Given this list of marker genes Slc30a1, Slc38a2, Nlgn1, Stxbp5, Slc22a2, Lin7b, Cacna1d, Prkca, Asic1, Rab5a, Cacna1e, Ddc, Slc32a1, Prkn, Gpr158, Mctp2, Syt11, Snca, Osbpl2, Slc6a7, Syt9, Cplx2, Th, Stxbp3 (syntaxin binding protein 3), Htr1d (5-hydroxytryptamine (serotonin) receptor 1D), Rph3al, Wnt7a, Slc22a3, Nf1, Efr3a (NCBI Gene Id 97947), Synj1, Rab3a, Snapin, Septin5, Syn2, Slc17a8, Slc18a2, Lrrk2, P2rx7, Slc28a2b, Slc1a7, Snap91, Snap25, Stx19, Ica1, Nat8l, Ppp1r9a, Cplx1, Vamp2, Xbp1, Fbxl20 (NCBI Gene Id 97750), Htr6, Psen1, Lin7a, Camk2a, Sv2a, Sptbn2, Itgb1, Cln8, Stxbp1, Stx4a, Fev, Adora2a, Slc17a6, Syt4, Rap1b, Unc13b, Stx3, Prepl, Slc17a5, Itgb3, Stx2, Slc6a8, Lin7c, Rims2, Git1, Pnkd, Tprg1l, Hcrt, Slc6a6, Sncg, Flot1, Cacna1b, Slc6a11, Otof, Ncs1, Edn3, Pdzd11, Cask, Cacnb4, Kcnh1, Prkcg, Slc28a2, Ptprn2, Nrxn2, Kmo, Npy, Trim9, Slc6a13, Mef2c, Slc22a1, Rph3a, Unc13a, Stx1a, Syt5, Sncaip, Kcnc3, P2ry1, Dtnbp1, Micu3, Rims4, Braf, Gpm6b (NCBI Gene Id 14758), Bglap2, Htr1b, Sv2c, Atp1a2, Syt2 (synaptotagmin II), Tacr2, Slc18a1, Slc29a3, Slc4a8, Rab3b, Pak1, Vps18, Syt7, Gfap, Atp2a2, Slc6a4, Erc1, Arl6ip5, Npy1r, Gpr151, Stx1b, Slc22a4, Rims1, Syt13, Cacna1a, App, Ctbp2 (NCBI Gene Id 52060), Dgki, Syn3, Tspoap1, Slc29a4, Per2, Baiap3, Slc1a6, P2ry4, Erc2, Htr2c, Slc29a1, Slc18b1, Syt12, Napa, Chrna3, Kcnj8, Fmr1, Kcnj10, Ppt1, Slc6a18, Nr4a1, Ngf, Grm8, Slc6a1, Abcc8, Bcl2l1, Cspg5, Park7, Nrxn1, Slc1a2, Slc29a2, Snap23, Bglap, Rap1a, Sphk1, Rab3gap1, Napb, Doc2g, Doc2b, Kcnc4, Rhot1, Cplx4, Git2, Stxbp5l, Ggcx, Slc6a3, Ppfia3, Slc10a4, Pclo, Pfn2, Rimbp2, Gdnf, Doc2a, Cadps2, Best1, Vamp1, P2rx2, P2rx1, Prkaca, Slc6a15, Drd4, P2ry2, Stxbp2, Sv2b (synaptic vesicle glycoprotein 2b), Syngr3, Slc6a2, Slc6a5 (NCBI Gene Id 233238), Ptger4, Prkcb, Rims3, Fbxo45, Syt8, Slc6a9, Gper1 (G protein-coupled estrogen receptor 1), Snap47, Cplx3, Snap29, Slc6a12, Ppfia2, Cadps, Syp, Nos1, Ntrk2, Mctp1, Prrt2, Grik5, Slc17a7, Dnm1l, Dvl1, Nrxn3, Slc18a3, Scrib, Slc6a17, Tor1a, Syn1, Drd2, Brsk1, Drd3, Unc13c, Syt1, Syt10, Syde1, Stx11, here is a description of the gene set: Mouse Gene Set: GOBP_NEUROTRANSMITTER_TRANSPORT species: Mus musculus The directed movement of a neurotransmitter into, out of or within a cell, or between cells, by means of some agent such as a transporter or pore. Neurotransmitters are any chemical substance that is capable of transmitting (or inhibiting the transmission of) a nerve impulse from a neuron to another cell.